The following is a description of a gene set: species: Homo sapiens Any process that modulates the frequency, rate or extent of the chemical reactions and pathways resulting in the formation of fatty acids, any of the aliphatic monocarboxylic acids that can be liberated by hydrolysis from naturally occurring fats and oils. Human Gene Set: GOBP_REGULATION_OF_FATTY_ACID_BIOSYNTHETIC_PROCESS, and this is the list of marker genes: CEACAM1, APOC1, AVP, ERLIN2, SIRT2, NR1H3, APOC3, MIR204, MIR132, MIR342, EIF6, SLC45A3 (solute carrier family 45 member 3, NCBI Gene Id 85414), INSIG1, BRCA1, ACADL, PDK4, LPGAT1, APOA5, CD74, GPIHBP1, MIR766, CYP7A1, DCAF5, ANGPTL4, GIP, WDTC1, INSIG2, FABP5, AVPR1A, PLAA, ACADVL, MIR185, MID1IP1, UBR4, ELOVL5, APOA4, MIR96, PIBF1, IL1B, PTGS2, KLHL25, MIR182, MLXIPL (MLX interacting protein like), APOC2, SIRT1, ERLIN1, ABCD2, MIR548P, PLA2G3, TRIB3, NR1H2, SCAP, MIR30C1, ABCD1 (ATP binding cassette subfamily D member 1), KAT2B, MIR33A